The following is a description of a gene set: Choreoathetosis Human Gene Set: HP_CHOREOATHETOSIS Involuntary movements characterized by both athetosis (inability to sustain muscles in a fixed position) and chorea (widespread jerky arrhythmic movements). species: Homo sapiens, and this is the list of marker genes: RNU4-2, NEUROD2, NDUFA1, ATM, SLC32A1, GRIN1, CDKL5, PNKD, SCN2A, GNAO1, KCNA1, NGLY1 (NCBI Gene Id 95041), GRIK2, LONP1, TSEN15, SUOX, SLC13A5, DCAF17, NDUFA13, GABRG2, SPR, SLC1A3, PIK3R5, MED23, TSEN34, PIGP, QDPR, HSPD1, POU3F3, VPS13A, PIGN, HSD17B10, TNR, GON7, MMUT, MRPS34, SCN1A, ATN1, ATP1A2, PDHA1, PIGQ, SEPSECS, TRIM8, SETX, ERCC6, MRE11, NUP62, DLAT, SPTBN4, NADK2, DDC, GTPBP2, NDUFA9, MT-ATP6, IREB2, SIK1, FTL, NUP54, SLC25A22, CERS1, SLC2A1, HCFC1, AP1S2, SCN8A, SYT1, GRM7, NDUFAF5, STXBP1, POLG, XPR1, MECP2, PNKP, SH2B1, PRRT2, FBXO28, HPRT1, ATP1A3, TUBB4A, GNAS, SLC30A9, TOE1, TSEN54, ST3GAL5, CACNA1B, SLC16A2, GCDH, TIMM50, ADCY5, ADAR, SCN1B (NCBI Gene Id 6324), COX20, SUCLG1, TSEN2, MICU1, NKX2-1, XPA, FRRS1L, PTS, CLPB, TMEM151A, GCH1, CASK, TRPM3, PANK2, PDE2A, CHKA, ELP2, PLP1, PNPT1, CACNA1A, DMXL2 (Dmx like 2), IRF2BPL, ATG7 (NCBI Gene Id 105376952), TMEM106B, GJC2, GUF1, ABHD16A, ARX, EIF2AK2, OPA3, MICOS13, SLC25A42, ERCC2, FBXL4